The following is a description of a gene set: Genes up-regulated in comparison of naive T cells at day 0 versus CD25+ regulatory T cell (Treg) treated with IL4 at day 3. CD25+ regulatory T cells develop in the thymus (nTregs), but may also be generated in the periphery upon stimulation of naive CD4 T cells under appropriate conditions (iTregs). The mechanisms that regulate the generation of peripheral iTregs are largely unknown. We used microarrays to gain insights into the molecular program of extrathymic Treg development. studied in species Homo sapiens Human Gene Set: GSE24634_NAIVE_CD4_TCELL_VS_DAY3_IL4_CONV_TREG_UP from publication Prots I, Skapenko A, Lipsky PE, Schulze-Koops H (PMID 21347372), and this is the list of marker genes: GYPC, DAZAP2, WDR45, CD6, SDR39U1, OR10H1, PIK3IP1, CXCR4, CEMIP2, RAP2B, IL6ST, SNX6, BTN3A1, TNFAIP3, IGBP1, MAB21L2, PLEKHA5, ASPH (aspartate beta-hydroxylase), ITM2B, JMJD1C, FCMR, RPS27, SLC16A6, FOXO1, RPL36, LEF1, CDR2, RPL35A, PLEKHA1, FYB1, SFMBT1, MCUB, RPL10L, MLLT3 (NCBI Gene Id 4300), KHNYN, NLRP1, RNF125, ZNF211, CTSF, SGSM2, VCPIP1, KLHL3, RABGAP1L, SRSF5, IFT20, MAX, DPEP2, ATP6V1G2, SLC2A4RG, MSX2, WTAP, H2BC21, BMAL1, ICAM3, ZNF184, ITGB7, ZNF266, MGAT4A, HIVEP2, KANSL2, PDCD4-AS1, ACSM3 (NCBI Gene Id 6296), SC5D, MTERF4, FBXW4, CACFD1, TOB1, SLC25A16, CDIPT, GADD45B, PPP3CC, FKBP9, SMAGP, PTGER1, AQP2, TUG1, ACVR2B, CD247, ELF2, ATG14, RPL23AP32, REX1BD, GABRA2, ARB2A, CD48, ZNF329, FGF9, VPS51, DGKZ, PYGM, BNIP2, IER2, TCF7, MAML3, PIK3R1, ZBTB40, CLK1, GARRE1, MAN2B2 (mannosidase alpha class 2B member 2), ACYP2, EXT1 (NCBI Gene Id 3966), ABLIM1, DNASE2, TENT5A, LEPROTL1, LITAF, PDE4B, TMEM243, SPSB3, STK38, R3HDM2, FYN, MVK, TMEM120B, VPS8, TSC22D3, ZFP36L2, CX3CR1, PTGER4, ARRB1, RASA3, LYRM9, TENT5C, SCAND1, OPTN, BTG2, ITGA6, SIK1, ZNF862, IQCK, TGFBR2, TRAPPC6A, ATM, GFOD3P, HSD17B11, KLF13, TRIM10, S1PR1, SYF2, FAM117A, HKDC1, FZD8, TMEM185B, SMPD1, SLC35C2, FAM174B, ZFAND3, GCC2, SMAD7, KBTBD2, ECHDC2, ITM2A, GNG12, PIAS1 (NCBI Gene Id 8695), CAST, ARHGEF9, PAX6, PPP2R2D, BTN3A3 (butyrophilin subfamily 3 member A3), CERNA1, GPA33, SERINC5, BRF2, CDC37L1, NBL1, ACSM5, COQ10B, ARHGEF18 (Rho/Rac guanine nucleotide exchange factor 18), PLEKHB1, TMPRSS5, ID4, RHBG (Rh family B glycoprotein), PFDN5, PPIEL, PSPN, HCN4, RPL11, FHIT, ATP6V1G1, LMBR1L, NGDN, TMCC1, IL16, FAM193B, CYTH1, BCL11B, TSPAN14, CUTA, RPL19, KAT2B, CSGALNACT1, FHL1, OSER1, L1TD1, FAM66D (family with sequence similarity 66 member D), EPN2 (epsin 2), TCTA, BBOF1